The following is a description of a gene set: studied in species Homo sapiens Human Gene Set: GOBP_POST_CHAPERONIN_TUBULIN_FOLDING_PATHWAY Completion of folding of alpha- and beta-tubulin; takes place subsequent to chaperonin-mediated partial folding; mediated by a complex of folding cofactors., and this is the list of marker genes: TBCD, TBCB, TBCA, TBCE, TBCEL, RP2, TBCC